The following is a description of a gene set: Human Gene Set: GOBP_POSITIVE_REGULATION_OF_CELLULAR_EXTRAVASATION Any process that activates or increases the frequency, rate, or extent of cellular extravasation. species: Homo sapiens, and this is the list of marker genes: CD47, MED23, ADAM8, PDGFD, MDK, PLVAP, IL1R1, XG, CD99, LYVE1, JAM3, CCR2, ICAM1, AGER, THY1, RIPOR2, CD99L2, FADD